The following is a description of a gene set: Human Gene Set: HP_SYNOSTOSIS_OF_CARPAL_BONES Synostosis of carpal bones studied in species Homo sapiens, and this is the list of marker genes: SALL4, ESCO2, EVC, PAX3, SHH, GLI1, HOXA13 (homeobox A13), NXN, SMOC1, PRKACB, PRKACA (protein kinase cAMP-activated catalytic subunit alpha), BHLHA9, DYNC2LI1, EVC2, ROR2, FGFR2, GDF5, LRP4, MACROH2A1, BMPR1B, FLNA, NOG, MAP3K7, APC, PITX1, LMBR1